Given this list of marker genes RNASEH2B, COMT, CPLANE1, SEC24C, PIGA, LSM11, SAMHD1, JMJD1C, FANCB, FIG4, GP1BB, ADAR, ATP6V1B2, RNASEH2A, UFD1, CHD7, RNU7-1, SF3B4, ARVCF, TCTN3, VANGL1, RNASEH2C, KIF7, SMOC1, TBX1, TREX1, RREB1, KIF14, VAC14, HIRA, GLI3, FUZ, IFIH1, HYLS1, TBC1D24, here is a description of the gene set: A defect of development of the brain characterized by congenital absence of the part of the brain that includes the olfactory bulbs, tracts, and other structures associated with the sense of smell. Arrhinencephaly Human Gene Set: HP_ARRHINENCEPHALY studied in species Homo sapiens